Given this list of marker genes NNMT, TRMU, TRDMT1, GCSH, GART, COMT (NCBI Gene Id 1312), BHMT, DNMT1, PJA2, FTCD, SHMT2, HNMT, CAD, ICMT, GAMT, ALDH1L1, GATM, here is a description of the gene set: studied in species Homo sapiens Genes in the cancer module 349. Human Gene Set: MODULE_349